The following is a description of a gene set: studied in species Homo sapiens Vaccination with attenuated live varicella zoster virus (VZV) can prevent zoster reactivation, but protection is incomplete especially in an older population. To decipher the molecular mechanisms underlying variable vaccine responses, T- and B-cell responses to VZV vaccination were examined in individuals of different ages including identical twin pairs. Contrary to the induction of VZV-specific antibodies, antigen-specific T cell responses were significantly influenced by inherited factors. Diminished generation of long-lived memory T cells in older individuals was mainly caused by increased T cell loss after the peak response while the expansion of antigen-specific T cells was not affected by age. Gene expression in activated CD4 T cells at the time of the peak response identified gene modules related to cell cycle regulation and DNA repair that correlated with the contraction phase of the T cell response and consequently the generation of long-lived memory cells. These data identify cell cycle regulatory mechanisms as targets to reduce T cell attrition in a vaccine response and to improve the generation of antigen-specific T cell memory, in particular in an older population. from publication Qi Q, Cavanagh MM, Le Saux S, Wagar LE, Mackey S, Hu J, Maecker H, Swan GE, Davis MM, Dekker CL, Tian L, Weyand CM, Goronzy JJ (PMID 27764254) Human Gene Set: QI_PBMC_ZOSTAVAX_AGE_50_75YO_CORRELATED_WITH_EXPANSION_OF_VZV_SPECIFIC_T_CELLS_TO_PEAK_AT_1DY_POSITIVE Genes positively correlated with expansion of VZV specific T cells (0d to peak) in peripheral blood mononuclear cell in seniors (50-75) after exposure to Zostavax, time point 1D, and this is the list of marker genes: LAMP2 (lysosomal associated membrane protein 2), MFSD1, FLI1 (NCBI Gene Id 2313), TACC1, CHST15, MED6, TALDO1, KDM2B (NCBI Gene Id 84678), PRSS23, MAP4K4, RASSF5, MOB1A, PRRC2C, IRF2BPL (interferon regulatory factor 2 binding protein like), ARPC5, RBM33, TRIM8, EIF3L, CAB39, PPP1R21, DPEP2, MANSC1, PGAM1, BTN2A1, UPF2, FAM8A1 (family with sequence similarity 8 member A1), EVI2B, ADGRG1, BANP, PELI1, FNBP1, PCBP1, STAT3, HNRNPH3, RNF19A, FBXO7, SLC11A1, LSP1, MTMR6, MTMR3 (NCBI Gene Id 8897), VRK3, SMAD4, CTDSP1, PGD, L3MBTL2, ZMIZ1, SLC6A6, ALDH2, REPS2, TGFBR2, CDK5R1, SNRK, SEC14L1, FRAT1, EFHD2, CTSS, RB1CC1, PGAM4, KIF5B, PFN1, ICAM3, SGK1, UBXN4, SGSM2, CTNNB1, EXO5, AP1M1, DHRS9, DHX38, GALM, WLS, SH3KBP1, MMP25, YWHAH, ABHD5, ATP8B2, FBXO33, LPAR2, HERPUD1, ANTXR2 (ANTXR cell adhesion molecule 2), JARID2, PARP1, CTDSP2 (NCBI Gene Id 51589), CYSLTR1, CALML4, VSIR, MYADM, CALM2, MME, WAS, PECAM1, GLB1 (galactosidase beta 1), PGRMC2, CXCR2, STK26, PPP1R18, SIRPA, NABP1, ERICH1, TAGLN2, SPG21, MAP3K14, FADD, ITGB2, RHOG, ZNF106, B4GALT5, PPT1, ACAP2, LILRB3, TGOLN2, KLHL22, CPQ, CLEC2D (C-type lectin domain family 2 member D), LRP10, GPR162, NPL, TCN1, SMAP2, LRRC25, SLCO3A1, PNISR, PSAP, PLCG2, VNN3P, ALOX5, NFE2, TXK, TSC22D3, PLOD1, SDHD, POTEKP, SLC40A1, TMED7, CMIP, FNDC3B (NCBI Gene Id 64778), TXNIP, TUBB (tubulin beta class I), RASSF2, SERPINA1, ARHGDIB, LRRC47, MYH9, TST, IWS1, OSBPL2, DPYD, SOD2, RIPOR1, FPR1, ZNF586, CCND3, TM2D3, B9D2, MAN2B2, HLA-H, RNPEP, CCR2, PDLIM7, KIAA0319L, SELL, FOXN3, FGD3, LMBRD1, RAB11FIP1, RNF130 (ring finger protein 130), RNF149, GAB2, EIF4G2, RESF1, MXD1, PAM, STX4, SIGLEC14, ADPRS, CHD1, PRR13, KDM3B, RBL2, KLHL24, SIGLEC10, IL1R2, HSPA6, AMY2A, MKNK1, CSF2RA (colony stimulating factor 2 receptor subunit alpha), PTBP3, HLA-B, ARAP3, TOMM20, AKIRIN2, LILRB2, RAB35, RNF38, CLEC16A, LPIN2, ADGRE3, RUNX2, UBAP1, CAST, HLA-F, RNF145, RXRA, CYRIB, ADD1, QPCT (glutaminyl-peptide cyclotransferase), PDE7A, CYTIP, TNFRSF1B, MTMR14, MBP, RCBTB2, SKIC2, ARHGAP30, IST1, TNFRSF10B, SARAF, ALOX5AP, SIPA1, UBE3C, PTOV1, ARHGAP25, LRG1, CAMK2G, DENND5A, CXCR4, LRRK2, MED16, TTC27, GPR65, N4BP2L2, FEZ2, CITED2, POGK, BTG1, GABARAP, JAK1, DDX3X, SPI1, CD14, SCYL1, TUBA1A, C5AR1, HSPA1A, SPAG9, MPPE1, MLKL, PANX2